The following is a description of a gene set: studied in species Homo sapiens Early satiety The condition of being unable to eat a full meal because of a feeling of fullness (satiety), or or feeling very full after eating only a small amount of food. Human Gene Set: HP_EARLY_SATIETY, and this is the list of marker genes: PRKCSH, TYMP, JAK2, LRP5, STAT3, SEC63 (SEC63 homolog, protein translocation regulator), POLG